The following is a description of a gene set: studied in species Mus musculus Mouse Gene Set: GOBERT_CORE_OLIGODENDROCYTE_DIFFERENTIATION Inadequate remyelination of brain white matter lesions has been associated with a failure of oligodendrocyte precursors to differentiate into mature, myelin-producing cells. In order to better understand which genes play a critical role in oligodendrocyte differentiation, we performed time-dependent, genome-wide gene expression studies of mouse Oli-neu cells as they differentiate into process-forming and myelin basic protein-producing cells, following treatment with three different agents. Our data indicate that different inducers activate distinct pathways that ultimately converge into the completely differentiated state, where regulated gene sets overlap maximally. In order to also gain insight into the functional role of genes that are regulated in this process, we silenced 88 of these genes using small interfering RNA and identified multiple repressors of spontaneous differentiation of Oli-neu, most of which were confirmed in rat primary oligodendrocyte precursors cells. Among these repressors were CNP, a well-known myelin constituent, and three phosphatases, each known to negatively control mitogen-activated protein kinase cascades. We show that a novel inhibitor for one of the identified genes, dual-specificity phosphatase DUSP10/MKP5, was also capable of inducing oligodendrocyte differentiation in primary oligodendrocyte precursors. Oligodendrocytic differentiation feedback loops may therefore yield pharmacological targets to treat disease related to dysfunctional myelin deposition. Oligodendrocyte core differentiation genes: up-regulated in Oli-neo cells (oligodendroglial precursor) at 10 h after treatment with PD174265, dexamethasone or isotretinoin. from publication Gobert RP, Joubert L, Curchod ML, Salvat C, Foucault I, Jorand-Lebrun C, Lamarine M, Peixoto H, Vignaud C, Frémaux C, Jomotte T, Françon B, Alliod C, Bernasconi L, Abderrahim H, Perrin D, Bombrun A, Zanoguera F, Rommel C, Hooft van Huijsduijnen R (PMID 19139271), and this is the list of marker genes: Map7, Numb, Pak5, Gm6211, Opcml, Rab2b, Oas1g, Brwd3, Ikzf5, Enpp6, Tal2, Tnni1, Dixdc1, Ugt8a, Ccng1, Sorbs1, Ndrg1, Elmo1, Inpp5k, Rnf13, Ankrd6, Hbp1, E2f1, Kcna1, Pak3, Ikbke, Abca1, Zkscan1, Ext1, Bcas3, Tnc, Narf, Aqp11, Trp53inp1, Slc25a27, Ptdss2, Mbp, Abat, Rgs2, Dscaml1, Il6ra, Atrn, Lrrn1, Cdk6